Given this list of marker genes Hspa1a, Ccl5, Fos, Cd74, Igkc, Lars2, Hspa1b, here is a description of the gene set: studied in species Mus musculus from publication Cui A, Huang T, Li S, Ma A, Pérez JL, Sander C, Keskin DB, Wu CJ, Fraenkel E, Hacohen N (PMID 38057668) Cytokines mediate cell-cell communication in the immune system and represent important therapeutic targets. A myriad of studies have highlighted their central role in immune function, yet we lack a global view of the cellular responses of each immune cell type to each cytokine. To address this gap, the authors created the Immune Dictionary, a compendium of single-cell transcriptomic profiles of more than 17 immune cell types in response to each of 86 cytokines (>1,400 cytokine-cell type combinations) in mouse lymph nodes in vivo. A cytokine-centric view of the dictionary revealed that most cytokines induce highly cell-type-specific responses. For example, the inflammatory cytokine interleukin-1β induces distinct gene programmes in almost every cell type. A cell-type-centric view of the dictionary identified more than 66 cytokine-driven cellular polarization states across immune cell types, including previously uncharacterized states such as an interleukin-18-induced polyfunctional natural killer cell state. Mouse Gene Set: CUI_T_CELL_CD4_IL17E_RESPONSE_DN Genes negatively differentially expressed in cell type: CD4+ T cell upon treatment with cytokine: IL-17E in mouse lymph nodes in vivo.